The following is a description of a gene set: Mouse Gene Set: MIKKELSEN_IPS_ICP_WITH_H3K27ME3 from publication Mikkelsen TS, Hanna J, Zhang X, Ku M, Wernig M, Schorderet P, Bernstein BE, Jaenisch R, Lander ES, Meissner A (PMID 18509334) Genes with intermediate-CpG-density promoters (ICP) bearing the tri-methylation mark at H3K27 (H3K27me3) in MCV8.1 cells (induced pluripotent cells, iPS). studied in species Mus musculus Somatic cells can be reprogrammed to a pluripotent state through the ectopic expression of defined transcription factors. Understanding the mechanism and kinetics of this transformation may shed light on the nature of developmental potency and suggest strategies with improved efficiency or safety. Here we report an integrative genomic analysis of reprogramming of mouse fibroblasts and B lymphocytes. Lineage-committed cells show a complex response to the ectopic expression involving induction of genes downstream of individual reprogramming factors. Fully reprogrammed cells show gene expression and epigenetic states that are highly similar to embryonic stem cells. In contrast, stable partially reprogrammed cell lines show reactivation of a distinctive subset of stem-cell-related genes, incomplete repression of lineage-specifying transcription factors, and DNA hypermethylation at pluripotency-related loci. These observations suggest that some cells may become trapped in partially reprogrammed states owing to incomplete repression of transcription factors, and that DNA de-methylation is an inefficient step in the transition to pluripotency. We demonstrate that RNA inhibition of transcription factors can facilitate reprogramming, and that treatment with DNA methyltransferase inhibitors can improve the overall efficiency of the reprogramming process., and this is the list of marker genes: Esrp1, Tfap2b, Thbs2, Lsmem2 (NCBI Gene Id 434436), Vtn, Espn, Akp3, Hoxb3, Vrtn, Inpp5j, Kcng4, Prss16 (serine protease 16 (thymus)), Tmem100, Bsx, Pcdhb2, Ccdc27, Chst1, Fxyd7, Sox6, Epn3, Lingo4, Gfi1b, Defb25, Lrrc4c, Cntnap2, Galntl6, Slamf8, Cfap57, Trpc5, Krt1, Cntnap1, Kcnj9, Zdhhc22, Cplx3, Zic4, Abca4, Tnf, Rtbdn (retbindin), Rfx4, Cxcl10, Fgf14, Nol4, Adcy6, Gm4861, Nr5a1, Pax5, Tmem119 (NCBI Gene Id 231633), Upk3a, Nkx2-6, Mc3r, Batf (NCBI Gene Id 54359), Tnnc2, Nr2f2, Pde1c (phosphodiesterase 1C), Cd72, Lrrtm3 (leucine rich repeat transmembrane neuronal 3)